Given this list of marker genes KCNJ2, CDH2, PLCG2, TMEM43, KCND3, here is a description of the gene set: Human Gene Set: HP_PRESYNCOPE studied in species Homo sapiens Presyncope Presyncope is a state of lightheadedness, muscular weakness, blurred vision, and feeling faint. Presyncope is most often cardiovascular in cause.